Given this list of marker genes PPDPF, PCBP2, ING3, NTAN1, MED28, NELFA, GMEB2, SHOC2, here is a description of the gene set: Genes distinguishing daunorubicin resistant and sensitive ALL (B- and T-lineage ALL); here - genes down-regulated in the drug resistant samples. studied in species Homo sapiens Childhood acute lymphoblastic leukemia (ALL) is curable with chemotherapy in approximately 80 percent of patients. However, the cause of treatment failure in the remaining 20 percent of patients is largely unknown. from publication Holleman A, Cheok MH, den Boer ML, Yang W, Veerman AJ, Kazemier KM, Pei D, Cheng C, Pui CH, Relling MV, Janka-Schaub GE, Pieters R, Evans WE (PMID 15295046) Human Gene Set: HOLLEMAN_DAUNORUBICIN_ALL_DN